The following is a description of a gene set: studied in species Homo sapiens Human Gene Set: WP_METAPATHWAY_BIOTRANSFORMATION_PHASE_I_AND_II Metapathway biotransformation Phase I and II, and this is the list of marker genes: CHST1, GSTCD, CYP4F22, TPMT, CHST2, GSTO1, CYP21A2, HS3ST3B1, NDST4, EPHX1, CYP2J2, GSTZ1, GSTO2, SULT2A1, CHST5, SLX1A-SULT1A3, EPHX2, CYP3A5, CYP4X1, GSTA1, UGT1A10, CHST7, HS6ST3, CYP19A1, CYP2A6, FMO5, CYP2A13, HS3ST1, CYP4B1, CYP2R1, CYP2S1, UGT2B15, CHST13, CYP27A1, GSTM5, NAA50, CYP2A7, NAT9, CHST4 (NCBI Gene Id 10164), MGST2, CHST3, GAL3ST3, SULT1A1, SULT1C4, GLYATL1, GSS, KCNAB1, COMT, CYP26C1 (NCBI Gene Id 340665), CHST10 (NCBI Gene Id 9486), CYP4Z1, GSTM4, SULT1B1, CYP11B2, CYP8B1, CYP2C9, CYP3A7, CHST9, GAL3ST2, CYP2E1, CYP39A1, CYP1B1, CYP1A2, CYP2U1, CYP4F3, CYP2D6, UGT2A1, HS2ST1, NAT10, GSTP1, AKR1C1, CHST14, CYP24A1, CHST6, HNMT, GSTA3, CYP3A43, CYP3A4, AKR1C2, GSTA2, CYP26B1, CYP2C18, UGT2A2, KCNAB3, NAT14, NAA40, CYP7A1, NDST2, NDST3, UGT2B7, SULT4A1, KCNAB2, GLYATL2, SULT1C3, MGST1, CYP27C1 (cytochrome P450 family 27 subfamily C member 1), NAT8, UGT2B28, NAA20, UGT1A4, GSTA4, CYP51A1, UGT1A5, GAL3ST4, AKR1B1, CYP17A1, NAA80, GSTT2B (NCBI Gene Id 653689), UGT2B17, SULT1A4, GPX4, HS6ST1, GPX2, CYP2B6, CYP11A1, UGT2B11, AKR1D1, FMO1, CYP4F8, HS6ST2, UGT1A6, CYP11B1, CYP4F11, NNMT, NAT8L, AKR7A3, GSTM3, UGT1A1, MGST3, GAL3ST1, CYP7B1, HS3ST5, GSTM1, BAAT, HS3ST2, FMO2, UGT1A9, CYP20A1, CYP26A1, GPX3, AKR1C4, HS3ST4, CYP2C8, CYP2F1, SULT1C2, NDST1, INMT, CHST12, GSR, CYP4F2, AKR1A1, FMO3, CYP46A1, CYP4F12, CHST11, SULT1E1, GPX5, GLYAT, CYP27B1, UGT1A3, HS3ST6, AKR1B10, GSTK1, CYP1A1, CYP4V2, UGT1A7, GSTA5, SULT2B1, HS3ST3A1 (NCBI Gene Id 9955), UGT2A3, UGT2B4, CHST8, GSTM2, NAA30, CYP2C19, CYP2W1, AKR1C3, SULT6B1, FMO4, GSTT2, NAT2, AKR7A2, SULT1A2